Given this list of marker genes RFC3, TAF11, RPS27A, PRKAA2, CDK5, BLM, ATRIP, RAD17, TP53RK, HIPK2, MAPK14, DYRK2, PIN1, TAF13, RMI1, MDM4, RFC4, TAF2, TBP, PLK3, CDK2, UBA52, RFC2, MAPK11, NBN, CSNK2B, CDK5R1, TOPBP1, AURKA, TAF3, TAF5, NOC2L, TPX2, STK11, PRKAG3, RPA2, PRKAG1, EXO1, ATR, TAF7L, BARD1, WRN, TAF7, UBC, TP53, CSNK2A2, KAT5, TAF9B (TATA-box binding protein associated factor 9b), CCNA2, CHEK2, TAF1, SSRP1, HIPK1, DNA2, RAD1, RHNO1, MAPKAPK5, UBB, TOP3A, CSNK2A1, TAF4, AURKB, TAF15, RPA3, TP53INP1, BRCA1, TAF10, RPA1 (NCBI Gene Id 6117), MRE11, BRIP1, ATM, TAF9, RAD9B, CCNA1, RMI2, NUAK1, RAD9A, CHEK1, TAF12, RBBP8, TAF4B, HUS1, TAF6, RAD50, RFC5, SUPT16H, TAF1L, PRKAB1, MDM2, PRKAA1, PRKAG2, PRKAB2, here is a description of the gene set: Human Gene Set: REACTOME_REGULATION_OF_TP53_ACTIVITY_THROUGH_PHOSPHORYLATION Regulation of TP53 Activity through Phosphorylation studied in species Homo sapiens